Given this list of marker genes UBR1, PNPLA6, LIPT1, FBP1, MED12, RFX6, CYP7B1, ABCB4, PRKCSH, TMEM67, IFT56, KMT2D (NCBI Gene Id 8085), HK1, IL12A, MTTP, TNFSF15, NT5C3A, INSR, PAFAH1B1, PEX2, UGT1A1, PEX19, SEMA7A, VPS50, NR1H4, OTX2, ATP8B1, ABCC2, SLC30A10, CDAN1, CPT2, CPOX, GBA1, OSTM1, AKR1D1, LRP5, TRMU, ALDOB, POU2AF1, G6PD, ODC1, IL12RB1, DCDC2, DGUOK, ZNF699, PEX14, LBR, IYD, NKX2-5, ALDOA, PAX8, GPX1, SLC51A (solute carrier family 51 member A), ABCD3, PRF1, ADK, TG, SLC35A2, KLF1, KIF23, SLC17A5 (NCBI Gene Id 6479), EPB42, GSR, FARSB, PKHD1, ROBO1, AMACR, IRF5, IARS1, TPO, NAA10, RHD, LYN, SLC2A1, SPTA1, HMBS (hydroxymethylbilane synthase), SLCO1B1, MMEL1, CASK, SEC63, SLC4A1, KCNN4, HSD3B7, RNU4ATAC, UROS, TSHB, PGK1, ABCB11, SLC10A1, OTC, EPB41, PKLR, NKX2-1, PIGA, TSHR, FOCAD, PIEZO1, POLG2, TFAM, DUOXA2, SLC5A5, MYO5B, FH, CHD8, SPTBN1, PFKM, IGF1, SLC26A4, RHCE, ATP7B, DUOX2, GYPC, SLCO1B3, BAAT, SPIB, GLRX5, SLC19A1, RHAG, GATA1, VPS33B, NHLRC2, SC5D, SLC2A2, POMC, UBE2A, VIPAS39, EIF2AK3, ANK1, SLC25A13, RACGAP1, TCEAL1, MPV17, WDR35, SPTB, FOXE1 (forkhead box E1), HBB, KIF12, TNPO3, here is a description of the gene set: Abnormal circulating bilirubin concentration species: Homo sapiens Human Gene Set: HP_ABNORMAL_CIRCULATING_BILIRUBIN_CONCENTRATION